The following is a description of a gene set: from publication Kasler HG, Verdin E (PMID 17470548) studied in species Mus musculus Genes down-regulated in DO11.10 cells (hybridoma) by expression of transciptionally activating form of HDAC7 and up-regulated by its transcriptionally repressing form. Histone deacetylase 7 (HDAC7) is highly expressed in CD4(+)/CD8(+) thymocytes and functions as a signal-dependent repressor of gene transcription during T-cell development. In this study, we expressed HDAC7 mutant proteins in a T-cell line and use DNA microarrays to identify transcriptional targets of HDAC7 in T cells. The changes in gene expression levels were compared to differential gene expression profiles associated with positive and negative thymic selection. This analysis reveals that HDAC7 regulates an extensive set of genes that are differentially expressed during both positive and negative thymic selection. Many of these genes play important functional roles in thymic selection, primarily via modulating the coupling between antigen receptor engagement and downstream signaling events. Consistent with the model that HDAC7 may play an important role in both positive and negative thymic selection, the expression of distinct HDAC7 mutants or the abrogation of HDAC7 expression can either enhance or inhibit the signal-dependent differentiation of a CD4(+)/CD8(+) cell line. Human Gene Set: KASLER_HDAC7_TARGETS_1_DN, and this is the list of marker genes: IGF2R, ITM2B, PARP16, SLC2A1, COL6A3, LGMN, SPP1, HK2, TTC19, PMM1, TRIP10, IGFBP6, SEMA4A, TANC1, C3, TXNIP, EDEM1